The following is a description of a gene set: Human Gene Set: KEGG_MEDICUS_REFERENCE_ACH_CHRN_PI3K_SIGNALING_PATHWAY Pathway Definition from KEGG: ACh -> CHRNA7 -> Ca2+ -> PI3K -> PIP3 -> AKT species: Homo sapiens ACH-CHRN-PI3K signaling pathway. Pathway ID: N01338. Pathway type: Reference. Pathway class: nt06214 PI3K signaling., and this is the list of marker genes: PIK3CD, PIK3CA, AKT1, AKT2, PIK3CB, CHRNA7, AKT3